The following is a description of a gene set: Mouse Gene Set: RASHI_RESPONSE_TO_IONIZING_RADIATION_4 The ATM protein kinase, functionally missing in patients with the human genetic disorder ataxia-telangiectasia, is a master regulator of the cellular network induced by DNA double-strand breaks. The ATM gene is also frequently mutated in sporadic cancers of lymphoid origin. Here, we applied a functional genomics approach that combined gene expression profiling and computational promoter analysis to obtain global dissection of the transcriptional response to ionizing radiation in murine lymphoid tissue. Cluster analysis revealed a prominent pattern characterizing dozens of genes whose response to irradiation was Atm-dependent. Computational analysis identified significant enrichment of the binding site signatures of NF-kappaB and p53 among promoters of these genes, pointing to the major role of these two transcription factors in mediating the Atm-dependent transcriptional response in the irradiated lymphoid tissue. Examination of the response showed that pro- and antiapoptotic signals were simultaneously induced, with the proapoptotic pathway mediated by p53 targets, and the prosurvival pathway by NF-kappaB targets. These findings further elucidate the molecular network induced by IR, point to novel putative NF-kappaB targets, and suggest a mechanistic model for cellular balancing between pro- and antiapoptotic signals induced by IR in lymphoid tissues, which has implications for cancer management. The emerging model suggests that restoring the p53-mediated apoptotic arm while blocking the NF-kappaB-mediated prosurvival arm could effectively increase the radiosensitivity of lymphoid tumors. from publication Rashi-Elkeles S, Elkon R, Weizman N, Linhart C, Amariglio N, Sternberg G, Rechavi G, Barzilai A, Shamir R, Shiloh Y (PMID 16314843) Cluster 4: genes repressed by ionizing radiation regardless of ATM status. studied in species Mus musculus, and this is the list of marker genes: Sp100, Hmgcs1, Gimap1, Gmfg, Dnaaf5, Sema4d (NCBI Gene Id 20354), Gpc4, Pygb, H2-Ob, Gm5796, Bcl2l11, Zap70, Rgs19, Plk4, Srp19, H2ax, Car8, Fam114a2, Herc4, Il27ra, Ifit3, Rmc1, Foxl1, Il7r (NCBI Gene Id 223338), Jph3, Sox2, Gm4739, E2f8, Alppl2, Ywhag, Rab7, Mtpn, Ifi203, Knop1, Prkar2a, Mfsd1, Zfp758, Cps1, Bbs9, Basp1, 1700097N02Rik, Dctpp1, Ifi204, Irgm1, Atp4a, Sf3a3, Ubap2l, Atp2a2, Tgtp1, Rad23b, Ifi205, Lgalsl, Lifr, Dynlt2a1